The following is a description of a gene set: studied in species Homo sapiens Reactome Pathway: Alanine metabolism The interconversion of alanine and pyruvate, annotated here, is a key connection among the processes of protein turnover and energy metabolism in the human body. part of: Metabolism of amino acids and derivatives, and this is the list of marker genes: GPT, GPT2